Given this list of marker genes XDH, MAPDA, ADA2, ADA, ENPP4, PNP, here is a description of the gene set: The chemical reactions and pathways resulting in the breakdown of any purine ribonucleoside, a nucleoside in which purine base is linked to a ribose (beta-D-ribofuranose) molecule. Human Gene Set: GOBP_PURINE_RIBONUCLEOSIDE_CATABOLIC_PROCESS species: Homo sapiens